Given this list of marker genes POLR3F, LARP1B, FUBP1, MIF4GD, CADM1, MIR223, KRAS (NCBI Gene Id 3845), PHB1, ATAD2, PRR16, BSG, JMJD4, RBM4, ABL1, TARBP2, GATA3, LTB, PLXNB2, CDK5RAP1, CD4, EBI3, TET1, C5, CD244, SIGLEC16, NRXN1, HNRNPLL, IRX1, CCL19, FAM76B, LILRB2, LARP4, IL1B, DNAJB9, HEG1, GPRC5B, KHDRBS1, IGHD, PHF2, HMGA2, LAMP3, ELAVL4, NR1H2, APOBEC1, MAVS, SSB, BRAF, SPON1, NOD1, IL10, ACTA2, TNFRSF14, LGALS9C, EIF5A, TGFB1, PRMT3 (NCBI Gene Id 10196), RBP4, ORM1, ARFGEF2, POU4F1, NAIP, PANX2, TNFSF11, FCGR1BP, NTRK3, ANGEL2, ADAM19, ATM, HAVCR2, ANK3, DNMT3L, TNP2, MIR640 (microRNA 640), MDM2, CD36, WNT16, POLR3A, PGR, FGF4, USP21, PELI1, FBLL1, ZC3H14, MIR101-1, SMYD5, PRKD1, AIF1, POLR3G (NCBI Gene Id 10622), AKAP12, SECTM1, RBM10, TADA3, C1QTNF3, BOLL, LILRA2, ATAD5, EXOSC6, IL12B, ROBO1, ITGB3, STOX1 (NCBI Gene Id 219736), NTSR1 (neurotensin receptor 1), NLRP12, NAMPT, HNRNPA0, MIR146A, ELAVL1, FCER2, RIPK2, GPER1, MEIOC, C5AR1, NGRN, EIF2AK4, WNT11, INS, ITGA3, NODAL, DDX3X, PIBF1, FLOT1, NBAS, NLRP3, MIR511, MARK1, CD40LG, ZFPM1, MIR133A1, BMPR2, RHOXF2B, PRKCZ, PIK3CG, GCGR, METTL8, LY96, CHIA, C17orf99, CCL3, F3, TRUB2, NAT10, MIR29B1, APOBEC3A, CNTF, RAMP2, TICAM2, ZSWIM8, TENT2, IL9, CSF1R, NR0B2, OGG1 (8-oxoguanine DNA glycosylase), DAZ3, CITED1, VSTM2A, SERP1, HMGB2, KLF4, MIURF, PLSCR1, TYK2, RPS6KA2 (NCBI Gene Id 6196, ribosomal protein S6 kinase A2), MUSTN1, MIF, NR4A3, CNTN2, EGF, SMO, EIF3C, CXCL8 (NCBI Gene Id 3576), SPHK1, ZEB2-AS1, ETV2, FXR1, FN1, PRDX6, YTHDF3, DND1, RIOK3, TLR9, XCL1, STAT5B, CDKN2A, INHBA, MYOCD, IL16, HSPA1A, AFAP1L2, PIK3R3, CCBE1 (collagen and calcium binding EGF domains 1), AKT2, CCL1, CLEC4E, RPL11, RPS27L, MITF, IL17F (NCBI Gene Id 112744), SPON2, ATMIN, CLU, IL7, GRHL3, CNGB1, FCN1, KAT7, SLC38A2, IRAK1, RAB27A, FGF9, ERBB3, ATF3, FASTKD2, DGKQ, OGT, NFIL3, TXK, MIR21, BMP10, STH, SRPK2, PPP1R15A, TMED2, TUSC2, CD46, NR1H4, CDK6, ATP13A2 (NCBI Gene Id 63919), TLE1, HLA-G, RUNX2, FOXP1 (forkhead box P1), IL20RB, PAWR, FCGR3A, CD81, TNP1, RBBP5, TRIM32, BMPR1B, CPEB3, FAM98A, NOS2, CD2, RGCC, THRAP3, LPL, TRMT112, RDX, HMHB1, IL17RC, CX3CL1, ADRA2A, ADAM8, CEACAM20, MIR33B, FADD, PLCG2, DLL1, BMP2, DNAJA4, SULF2 (sulfatase 2), PTGER4, PTPN11, NSUN5, ALKBH1, MIR20B, TARDBP, TRAF3, LIN28A, IL6, OAS1, ZBTB7B, IL36A, LCN2, SCIMP, CRP, TENT5B, RHOXF1, KPNA2, SMAD1, IRF8, FXR2, ALKBH4, HABP4, LEF1, WDR5, EPHX2, SRSF1, PASK, KLRC4-KLRK1, MCOLN2, MAF, EIF2B5, ACVR1B, ASH2L, ALDH1A2, TNC, RBM22, ZAR1, NR5A2, HTR2A, IL17D (NCBI Gene Id 53342), OVOL2, NKX2-5, ANXA1, CRLF2, ZCCHC3, APEX1, CLEC3B, NFE2L2, NSD2, LUM, STOML2, APOBEC2, HLA-A, PINK1, MIR212, MIR182, NLRP10, ROCK2, IL18, LACC1, UCN, RPL26, GATA4, RBMX, DAZAP1, IL32, MIR769, NGF, PID1, ADIPOQ, SLC24A3, CALCR, SRY, CHUK, HSPB1, AVPR2, STX4, TANK, MIR501, SP1, SAMD4A, WBP2, TESC, TRAF6, SOX11, CD28, PGC, AGO1, LILRA5, RPUSD3, EIF4A3, FCGR1A, SHLD3, MIR205, FGF8, PYDC1, CCL5, CLDN5, SERPINB7, HLA-F, PLCB1, RAET1G, GATA2, HNRNPAB, MAPK11, NKD2, FGR, FAM98B, IRF1, BMPR1A, AKT1, ADORA2B, PIK3R1, IGF2BP2, STAT1, RBM47, CRYZL2P-SEC16B, TLR7, FMR1, APOBEC3F, TIRAP, NCK1, MMP8, PAIP1 (poly(A) binding protein interacting protein 1), TENT5A, S100A13, LAPTM5 (NCBI Gene Id 7805), MED1, SH3BGRL, E2F1, MPV17L2, MIR183, POU3F1, DTNBP1, FBLN1 (fibulin 1), CLEC9A, UHMK1, TRUB1, RBBP9, IL17A, XIAP, MIR144, SCRIB, LARP1, HOXA5, IL2, RPS6KB1, RUNX1 (NCBI Gene Id 861), PRG2, GDF7, TRMT10C, TNFRSF8, MYOM1, HMCES, CYBA, HMGN5, ALOX12B, AIM2 (absent in melanoma 2), CALR, ZCCHC13, CLDN19, RSAD2, KRT17, NAT8, DEFA5, WNT5A, PIP, CAMK4, NTS, IFNL1, IL12RB2, BMP4, RBM3, ZPR1, BMP6, PRG3, EDAR, IL7R, PKD2, HHLA2, SAA1, IL1RAP, IRF7, AGT, ZP3, USP22, AZU1, NOX1, CDK1 (NCBI Gene Id 983), KDM1A, NOS3, TMF1, PTGS2, LCK, MSN, SECISBP2, QKI, NKX3-1, HGS, SMAD3, ROCK1, CD86, HIF1A, AGR2, GAS6, IL6ST, CD3E, DNM3OS (DNM3 opposite strand/antisense RNA), ANK2, LRRK2, TGFB2, KDM5B, UPF3A, PLA2G3, HOXD3, MMP12, RAD21, ELOC, MAP2K2, WARS1, OTUD6B, JAK2, PARK7, RAB2B, HGF, ACTA1, AGO3, MIR132, CYBB, IFI16, IL23A, TFRC, TRIM27, BRD7, CDH3, CRH, MIR27B, HFE, CEBPE, PPP3CA, HYAL2, LGALS9, IL15, NCK2, FGFR4, UBR5, SOX10, ANGPT1, TRIM16, NR1I2, SERPINE1, KPNA6, TET2, C1QTNF4, FZD5, ARRB2, CCR2, CELF3, PPARG, NOG, TNFSF13, POLR3C, IL13RA1, VIP, RCC1L, ENO1, PKP1, NCBP1, TCF12, IL17B, OSR2, CD274, WNT10A, TTC21B, ACTC1, MBP, GUF1, GALNT2, SETX, DDX21, SETD4, RELA, RBMY1E, IL5, HSF1, PTPRJ, EMILIN1, CCDC88B (coiled-coil domain containing 88B), TLR4, ADM2, RBM4B, YBX1, HILPDA, ADCYAP1, MAPK14, IL27, GARIN5A, TGFBR3, HMX2, YAP1, RORA, TNF, IL1R1, TP53BP1, IL6R, WNT7A, IRF3, CCL2, YTHDF2, BRCA1, SERPINF2, POLR3D, MIR509-1, MYLK2 (myosin light chain kinase 2), CTCFL, CSDE1, KMT2A, SMARCB1, IAPP (islet amyloid polypeptide), GATA5, ZC3HAV1, DHX36, L3MBTL3, NLRP1, EIF5A2, SGF29, CARD8, CD74, SIRT1, DHX29, GJA1, SLC11A1, FUS, PKP3, TOB1, LIN28B, RLF, TENT4B, NKX2-1, CLEC6A, WNT3, MAPK13, RBM14, ABCC8, NLRC4 (NCBI Gene Id 58484), BCDIN3D, IL13, ERP29, NLRP9, NFATC2, NR2E3, ANXA2, IL12A, IFIH1, WDR77, SEC16B, CELF4, ARRDC4, PRKCQ, TMEM106A, CIRBP, POLR2G, NCL, MSH2, EIF4G1, SLC26A9, NKX2-2, ERN1, DAZ2, SPRY2, FAM47E, AGER, MYCN (NCBI Gene Id 53360), CLECL1P, CD7, TTN, EPX, ADAM17, MEF2A, RNF135, GPSM3, SETD2, ATF4, RMND1, CTCF, A1CF, DPY30, LRRC32, SHH, CALCOCO1, LY9, IL27RA, F2RL1, ITGAX, IL1RL1, HSPD1, MAD2L2, THBS1, DDRGK1, CTNNB1, U2AF2, IL33, MYC, ORM2, STAP1, HLA-E, HMGB1, SELENOK, IL4, VPS35, AMH, FRMD8 (NCBI Gene Id 83786), DEFB124, PDCL3, ATF2, TNFSF4, ZNF804A, HSPA1B, UPF1, PIWIL2, INAVA, PDE4D, ZNHIT1, CASP8, RPL5, SRC, KAT6A, VSIR, CLEC5A, FTX, STAT5A, KAT8, RAB1A, POU3F3, TRIM65, IL26, SORL1, MIR324, MZB1, ZNF580, DAZ4, ARID1B (NCBI Gene Id 645070), GSK3B, CD6, TRAF2, PHB2, BMP7, WHRN, CDH5, CNN2, SOD1, ISL1, ID2, MIR15B, ELOB, YBX3, HCFC1, RFTN1, RBMY1A1, C3, PAX6, AICDA, NMBR, GSDMD, NUP98, CTIF, METTL3, HAND2, ADAR, WNT6, PAEP, EIF2AK2, HES1, MIR149, SLC39A5, IGF2BP1, RBMS3 (RNA binding motif single stranded interacting protein 3), TENT5C (NCBI Gene Id 54855), LINC-ROR, METTL14, AKIRIN2 (akirin 2), NOCT, MACROH2A1, F12, CITED2, IQGAP3, TIFAB, CGAS, DHX34, ZC3H10, S100A10, MIR506, PRMT5, STAT3, CD34, PPM1F, DAZL, TLR6, PTPRC, MYB, LDLR (low density lipoprotein receptor), KMT5C, PADI2, AIRE, IL4R, TRIM56, PANX1, PRKDC, TYROBP, CEBPA, ACTG1, MALT1, FASTKD3, KLRF2, METTL5, LMNA, PDE2A, SLC6A4, CLCF1, ID4, FFAR2, FOXP3, PRMT1, KLRK1, PDE4B, WNT3A, MBIP, HPN, HNRNPC, RBMY1D, BCL10, KLK3, TLR5, CYP26B1, PLP1, ACTG2, APOA2, TLR1, IGF2BP3 (NCBI Gene Id 10643), DLX5, NPM1, TLR3, HLA-DPB1, TLR8, LILRB1, DDIT3, TRIM24, NLRP2, P2RX7, REST, MIR140, SOX9, MAFG, HPX, MIR106A, FCGR2C, SLAMF1, B2M, PTGFR, CD40, HNRNPD, AGO2, EGR1, PDCD5, LBP, CD80, EIF3E, CARD11, MIR675, METTL16, IDO1, TFAP2A, TENT5D, VPS72, RBPJ, RPS3, SNRNP70 (NCBI Gene Id 6625), RPS6KB2, CTSH, EEF2, TP53, MLH1, DDX1, POU2F2, KDM1B, DRD2, ADAM10, VTCN1, SLC24A4, EIF6, DGCR8, POMC, ZCCHC4, RBMXL1, EIF4G3, TP53INP1, PPARGC1A, FCER1G, RPL23, TRIM6, SNW1, CAV1, DLL4, PRPF19, SASH3, FSHB, BTNL2 (butyrophilin like 2), PRKN, MAZ, MUSK, LIF, DHX33, CASP1, DHX9, SMAD4, SAMD1, OLFM1, FLT4, RPS7, YTHDF1, ZNF750, MED23, HMOX1, RBM24, MIR29A, APPL1, PIK3CD, KLK7, MIR657, SPTBN1, GDF2, CSF2, YY1, APP (amyloid beta precursor protein), LAMTOR5, MYH9, HINFP, MIR16-1, TLR2, ARID5A, LTA, RIGI, IGF1, LIMS1, STAT6, ASTL, AXIN2, LRP3, FEV, RAMP3, STING1, PAXIP1, CYRIB, DEFB131A, PPARD, PHF8, KPNA7, SRSF5, TBX21 (NCBI Gene Id 30009), IL1RL2, TOMM70, SEMA7A, MIR1246, CXCL17, WT1, F2R, APOB, LGALS9B, FCGR2B, RLN2, BTN3A2, MIR23A, EIF4ENIF1, RBMY1F, RBMY1J, RIPK1, TGFBR1, PRKAA1, EPHB2, BATF, TMIGD2, ALOX15B, TSLP, RPS4X, SPI1, CRTAM, NOD2 (nucleotide binding oligomerization domain containing 2), PRKCH, PQBP1, ADAM2, TREM2, PRDM1, ELANE, BCL3, HOXB-AS3, LEP, TIGIT, MEN1, DNMT1, PYM1, ZNF683, IL17RB, TRIM15, UQCC2, CNBP, NFAT5, ZMPSTE24, ETS1 (NCBI Gene Id 2113), FFAR3, CNTN1, N6AMT1, RPUSD4, LARP4B, MDK, DHX58, ITK, CLDN3, IKBKG, SFRP4, TET3 (NCBI Gene Id 23298), AVP, OCLN, CYP1B1 (NCBI Gene Id 1545), MIR27A, KIT, ZFP36 (NCBI Gene Id 7538), USP50, RARA, ID3, DENND1B, POU2AF1, ABCF1, OAS2, NOC2L, IL17RA (interleukin 17 receptor A), DNAJC3, IKBKE, ADTRP, OPA1, PDCD10, SHLD2, HDAC2, VIM, GAPDH, C3AR1, MIR206, GPR65, ARNT (aryl hydrocarbon receptor nuclear translocator), EZR, CD83, PNP, APOBEC3C, EXOSC3, NRDE2, TRAF3IP2, TRAF5, GRIA1, NR5A1, ITGB8, CEBPB, NTRK2, TDG (NCBI Gene Id 93091), EREG, SLAMF6, G3BP1, MIR34A (NCBI Gene Id 407040), MT3, TMEM119, RHBDD1 (rhomboid domain containing 1), HNF1B, ERBB2, SHLD1, NRDC, GLYR1, IL21, PCIF1, DROSHA, IRAK3, SOX17, NFATC4, RIF1, MAPK9, C1QBP, OIP5-AS1, PTPN22, GSN, PSEN1, MMP14, HTR2B, RHOXF2, RNF207, GLMN, VEGFA, RBMY1B, FOXC1, IFNG, MIR145, ATP6AP2, OSR1, TOR2A, PLD1, CHI3L1, EDA, NOTCH1, DAZ1, FCGR2A, CD58, GPI, FER1L6, SIRT7, CALCA, ZBTB20, PANX3, SCX, BAG2, MYD88, NICOL1, DKK1, CASR, PLGRKT, PKM (pyruvate kinase M1/2), SNF8, MIR92A1, RET, SOX8, RIMS1, NWD1, BLNK, XBP1, ERCC6, VAMP3 (NCBI Gene Id 9341), IL18R1, CD160, CD14, VDR, MAP3K7, RBM20, MIR30B, C1QTNF1, TNFRSF4, EIF5AL1, AGPAT1, USP16, RBM46, CREB1, POLR3B, BARHL2, ARID1A, RAB7B, PLAG1, ITGA2, OSM, CAMP, SYK, BTN3A1, TWIST1, PLA2G1B, BRDT, MIR125A, MEFV, BCL11A, MIR520C, TICAM1, MAPK8, POLDIP3, CLEC12A, PABPC1, HRAS, ANGPTL8, SPN, SLC2A10, IRF4, IL12RB1, CLEC7A, SULF1, TENT4A, NFAM1, DNMT3B, KIR2DL4, FOXD1, AGPAT2, CLNK, KLKB1, PYCARD, MEF2C, HLA-DPA1, IRF5, IL23R, NIBAN1, IL1A, CD55, IL34, FGF2, POLR2A, ID1, COA3, SYNCRIP, TRA2A, PMS2, TRAPPC2B, ARHGEF2, MIR17, CUX2, CD200, MIR130A, ARX (NCBI Gene Id 619216, aristaless related homeobox), CEBPG, TTBK1, CARD9, ODAM, SMARCA4, DYRK1A, EXOSC10, EPB41L4B, CLNS1A, MTOR, NMB, BTK, ZC3H12A, KAT2B, GDNF, DDT, KAT2A, MELTF, TBK1, TRPV4, IFNGR1, MED26, EP300, GBP5, AR, NAT8B, NRL, PTH, KMT5B, POSTN, RARG, CD276, RTN4, PRKD2 (NCBI Gene Id 51519), EIF2AK3 (eukaryotic translation initiation factor 2 alpha kinase 3), NOX5, UAP1, RBM38 (NCBI Gene Id 55544), PLA2R1, CCR7 (C-C motif chemokine receptor 7), FUBP3, HNRNPU, ISG15, MAP2K1, TMED10, FERMT1, HK1, HDAC1, C14orf93, GSK3A, TCF23, UNC93B1, STMP1, MAPKAPK2, CELF1, PIK3CB, SCAMP5, SMARCD1, KLK5, TFR2, IL2RG, CD37, LURAP1, TAF15, HMSD (histocompatibility minor serpin domain containing), OAS3, IREB2, CD226, SPHK2, UPF3B, CSF1, TRA2B, HPSE, AFDN, MIR548C, PF4 (platelet factor 4), SMAD2, ENSG00000293600, SLC7A5 (solute carrier family 7 member 5), PDGFB, TRAF3IP3, ATAD2B, HSP90AA1, here is a description of the gene set: Any process that increases the frequency, rate or extent of gene expression. Gene expression is the process in which a gene's coding sequence is converted into a mature gene product (protein or RNA). Human Gene Set: GOBP_POSITIVE_REGULATION_OF_GENE_EXPRESSION studied in species Homo sapiens